The following is a description of a gene set: species: Mus musculus Mouse Gene Set: GOBP_TUMOR_NECROSIS_FACTOR_MEDIATED_SIGNALING_PATHWAY The series of molecular signals initiated by tumor necrosis factor binding to its receptor on the surface of a cell, and ending with the regulation of a downstream cellular process, e.g. transcription., and this is the list of marker genes: Hipk1, Tradd, Rbck1, Otulin, Pias4, Birc2, Tnfrsf11b, Stat1, Rffl, Aim2, Ptk2b (PTK2 protein tyrosine kinase 2 beta), Peli3, Tnfsf11, Tnfrsf18, Ilk, Txndc17, Commd7, Chuk, Apoa1, Syk, Gps2, Tnfrsf17, Nr1h4, Hspa1b, Adipoq, Pycard, Card14, Krt18, Ikbkb, Foxo3, Mmp8, Cd70, Nfkbia, Cdip1, Sphk1, Tnfsf13b, Trim32, Eed, Rack1, Ripk1, Gas6, F2rl1, Spata2, St18, Traf2, Naip5, Tnfrsf13c, Lims1, Tnfsf18, Tjp2, Cpne1, Cyld, Pias3, Actn4, Eda2r, Rnf31, Krt8, Tifa, Birc7, Tnfrsf11a (NCBI Gene Id 21934), Ccdc3, Laptm5, Traf1, Rela, Ube2k, Jak2, Rraga, Casp1, Traf3ip2, Naip6 (NLR family, apoptosis inhibitory protein 6), Tmsb4x, Sharpin (SHANK-associated RH domain interacting protein), Ikbkg, Tnf, Tmc8, Adam17, Naip1, Nol3, Ppp2cb, Prkn, Plvap, Cldn18, Umod, Tnfrsf1a, Ext1, Tnfrsf1b, Ptpn2, H2bc21, Xiap, Nkiras2, Traip, Nsmaf, Nkiras1, Trp53, Naip2, Traf3, Tnfrsf4, Tank, Dicer1